The following is a description of a gene set: species: Homo sapiens Human Gene Set: GOBP_REGULATION_OF_B_CELL_DIFFERENTIATION Any process that modulates the frequency, rate or extent of B cell differentiation., and this is the list of marker genes: IL10, SYK, NFAM1, HMGB3, INHBA, CD27, INHA, ZFP36L2, CARD11, MIR17HG, FCRL3, IL2, IL4I1, NCKAP1L, INPP5D (NCBI Gene Id 653796), IKZF3, BAD, STAT5A, IL7, BTK, CYLD, SFRP1, MMP14, SPI1, PTPN6, PCID2, PPP2R3C, STAT5B, CR1 (complement C3b/C4b receptor 1 (Knops blood group)), DDRGK1, ID2, IL2RG, BCL6, XBP1, SLAMF8, ZFP36L1, TLR9